The following is a description of a gene set: Mouse Gene Set: ZHANG_UTERUS_C8_NK_CELL species: Mus musculus Table S2: Representative genes of each cell cluster from publication Zhang L, Long W, Xu W, Chen X, Zhao X, Wu B (PMID 35669188), and this is the list of marker genes: Rpl37rt, Ptpn18, Rpl13, Stat3, Rps16, B2m, Serpinb9, H3f3b, Pabpc1, Cyrib, Gm10736 (predicted gene 10736), Rpl4, Rps6, Thy1, Rps13-ps2, Psme2, Cd52, Klri2, Hmgb2, Cmtm7, Evl, Gm13588, Rpl23a, Rps18 (NCBI Gene Id 20084), S100a10, Gm14303, Stk17b, Rpl35, Crip1, Actr3, Selplg, Gmfg, Gzmb, Rps15a-ps6, Nr4a2, Ctsw, Rps11, Sh2d2a (SH2 domain containing 2A), Il2rg, Vps37b, Gimap4, Klra4, H2-Q6, Klra13-ps, Ifngr1, Sumo1, Ddx5, Sh3bgrl3, Serpinb6b (NCBI Gene Id 20708), Rpl35rt, Gm13436, Litaf, Rgs1, Zfp36l2, Ubald2, Irf8, Supt4a, Rnaset2b, Klre1, Klra8, Eif1, Fxyd5, Rpl36, Rps13, Tiprl, Lck, Arpc3, Tnfrsf9, Xcl1, Sub1, Rac2, Arpc5, Oaz1, Rnaset2a, H2-Q7, Car2, Rps18-ps5, Cfl1, Rps11-ps1, Cd53, Klrd1, Rps3, Hcst, Trbc1, Arpc1b, Cd47, Coro1a, Tyrobp, Rgs2, Sec11c, H2-D1, Ostf1, Rpl27a, Il2rb, Sp100, Calm1, Anxa2, Ptprcap, Gpr132, Cotl1, Serinc3, Srgn (NCBI Gene Id 19073), Cyba, Rps27rt, Tmed5, Gm3788, Cenpa, Srsf5, Rpl18a, Cd2, AW112010, Dusp5, Mbnl1, Rpl3, Uba52, Rps23-ps1, Ccr2, Klra7, Gm15427, Bhlhe40, Clic1, Rps6-ps4, Fam107b, Cnbp, Dennd4a, Id2, Nkg7, Klrk1, Rpsa, Gimap6, Rps23, Prdx6, Rbm3, Ly6e, Rpl32, Cd7, Ppp1ca, Jak1, Bcl2l11, Calm2 (calmodulin 2), Saraf, Ptpn22, Mdh1 (NCBI Gene Id 83566), Rps16-ps2 (NCBI Gene Id 100048153), Psmb8, Gm9843 (predicted gene 9843), Gm11478, Arpc2, Isy1, Rpl3-ps1, Eef1a1 (NCBI Gene Id 13627), Laptm5, Spp1, Dgat1 (NCBI Gene Id 96948), Arhgdib, Bin2, Ptprc, Hilpda, H2-K1, Rpl13a, Ppia, Ccl5, Lcp1, Tmsb4x, Ms4a4b, Pfn1, Hnrnpf, Fasl, Tmsb10, Actg1, Nop53, Ccl4, Crem, Ets1, Rps15a, Fcer1g, Fosl2, Gpi1, Shisa5, Tnfaip3